Given this list of marker genes Taar5, Gngt1, Gngt2, Mc2r, Gpr176, Vip, Avp, Htr6, Glp2r, Ptgir, Rxfp2, Ghrhr, Ptger4, Ramp3, Adm2, Gip, Gng3, Mc3r, Adm, Fshb, Gcgr, Rln3, Gng7, Sct, Fshr, Gpr15, Grk5, Mc4r, Iapp, Gnb2, Gng8, Ghrh, Pomc, Adora2a, Cga, Gpr83, Gpr20, Gcg, Prkar1b, Adcyap1 (adenylate cyclase activating polypeptide 1), Vipr2, Taar8c, Ptgdr, Gnb5 (NCBI Gene Id 14697), Glp1r, Grk6, Gipr (gastric inhibitory polypeptide receptor), Pde7b, Htr4, Pth2, Gper1, Gpr84, Hrh2, Gnb3, Npsr1, Taar8b, Drd5, Mc5r, Pth2r, Arrb2, Crhr2, Gng5, Pde2a, Gng10, Gng4, Itga5, Pde8a, Vipr1, Adrb1, Pth1r (NCBI Gene Id 19228), Adrb3, Gphb5, Ptger2, Gpr150, Gpr27, Shc1, Crhr1, Pde10a, Prkacb, Taar1, Avpr2, Mc1r, Taar3, Pde1b, Gpbar1, Htr7, Prkaca, Gpha2, Prkar2b, Tshr, Gng11, Taar9, Sctr, Grk3, here is a description of the gene set: electronically inferred by orthology from the curated human pathway This event has been computationally inferred from an event that has been demonstrated in another species.<p>The inference is based on the homology mapping from PANTHER. Briefly, reactions for which all involved PhysicalEntities (in input, output and catalyst) have a mapped orthologue/paralogue (for complexes at least 75% of components must have a mapping) are inferred to the other species. part of: GPCR downstream signalling species: Mus musculus Reactome Pathway: G alpha (s) signalling events